The following is a description of a gene set: Reactome Pathway: GSK3B and BTRC:CUL1-mediated-degradation of NFE2L2 In addition to KEAP1:CUL3-mediated degradation in the cytosol, NFE2L2 appears to also be subject to degradation by a BTRC:CUL1 E3 ligase. Degradation by the BTRC:CUL1 pathway is mediated by interaction with the NFE2L2 Neh6 domain, and is stimulated by GSK3B-mediated phosphorylation of the Neh6 DSGIS motif. GSK3B-dependent Neh6 phosphorylation is primed by the phosphorylation of a cluster of adjacent serines by unknown kinase(s). Inhibitory phosphorylation of GSK3B by activated PI3K/AKT signaling relieves BTRC:CUL1-mediated NFE2L2 degradation and provides a biochemical link between activated PI3K signaling and increased NFE2L2 pathway activity. studied in species Homo sapiens part of: Nuclear events mediated by NFE2L2, and this is the list of marker genes: PSMA1, PSMB5, BTRC, RBX1, UBC, PSMB2, PSMA2, SKP1, PSMC2, PSMC1, PSMA5, NFE2L2, PSMD6, CUL1, PSMD14, RPS27A, PSMD12, PSMA6, PSMD1, PSMD13, UBA52, ADRM1, PSMA7, PSMA3, PSMD8, GSK3B, PSMB7, PSMD7, PSMD11 (proteasome 26S subunit, non-ATPase 11), PSMB1, PSMA4, PSMB4, PSMC6, PSMC5, UBB (NCBI Gene Id 91253), PSMC3, PSMB3, PSMD3, PSMB6, SEM1, PSMD2, PSMC4